The following is a description of a gene set: species: Homo sapiens Any process that activates or increases the frequency, rate or extent of meiosis. Human Gene Set: GOBP_POSITIVE_REGULATION_OF_MEIOTIC_NUCLEAR_DIVISION, and this is the list of marker genes: NPR2, MEIOSIN, STRA8, DAZL, UBE2B, OOEP, WNT5A, SIRT2, PIWIL2, NPM2, MSX2, PRDM9, DMRT1, MSX1, PLCB1, WNT4, RAD51AP1